Given this list of marker genes CMC1, P2RX7, ZNF627, ZCCHC12, WDPCP, TNFSF11, TMLHE, YPEL2 (NCBI Gene Id 388403), ARHGAP5, ZC3H7B, ANGPTL1, FBXL17, FUNDC1, DHX58, RCL1, IRF7, VPREB1, ACOX1, ZEB1, CLMP, CYP4V2, HSD17B11, ZNF365, RENBP, SNN, HSPH1, PKP4, EIF2AK1, BCOR, ALDOA, SASH3, TESC, FAM120B, SETD5, ASB7, FAM131A, MAP1B, C6orf118, DSE, ARRB1, KRTCAP3, MEAK7, IL6R, PPARGC1B, RIGI, TIGD2 (tigger transposable element derived 2), SELENOP, VPS13C, NBR1, ZNF711 (NCBI Gene Id 7552), CTNS, MZT2B, LIAT1, IQUB, TNIP1, GARIN3, MAPRE3 (microtubule associated protein RP/EB family member 3), NR3C2, RAB11FIP2 (NCBI Gene Id 22841), ZNF48, XAF1, MRPL23, TAF5L, CD2AP, MTR, CRTC1, DLG3, ZBTB4, XPC, KDM5B, GUCA1B, AKAP6, ICA1L, MYB, SESN3, LDLRAD4, CELF3, CALCOCO1, AVPR1A, RGMB, VRK1, MFSD9, GNPNAT1, RAMP3, TTC39C, STX4, ZCCHC24, TRPM1, MCCC2, CCDC141, CHDH, AFP (NCBI Gene Id 174), MTMR7, TNIP2, PTRH1 (NCBI Gene Id 138428), SH3RF1, OSGEP, KDM3B, SERAC1, INPPL1, MGARP, AGO1, IFT74, ASB3, DECR1, PFN2, ZNF106, SYT11, SLC25A36, CORO6, ISCA2, GADD45B, QPRT, TRPM6, CCR4, RNF19A, TRHR, BTBD2, DYNLT5, ATRAID, EVI5, KRT35, HES5, RWDD3, TNF, EXT1, WDR59, ANGPTL2, ZMYM4, FTL, HS1BP3, BAG5, NFKBIA, FAM168A, UBL5 (ubiquitin like 5), HSBP1, ATG2B, CTSS, NBN, PHF21A, MYCBP2, PFKM, CCDC91, ATP1B1, C19orf12 (chromosome 19 open reading frame 12), ARID5B, C1orf185 (chromosome 1 open reading frame 185), SLC3A1, DZIP1, SLC36A2, TGFB2, CTH, CALHM6, MAX, UTP14A, FAM217A, PCCA, XKRX, CDH23, ZNF518B, DNAL1, ART3, EGLN3 (egl-9 family hypoxia inducible factor 3), BPHL, TOX2, STAT1, OPALIN, AKAP11, TRMT1L, ABCG1, ZHX2, UBE2D1, TMPRSS4, CBX6, UBASH3A (ubiquitin associated and SH3 domain containing A), COMMD2, AREL1, HSPBAP1, C3orf33, WDFY2, SBSN, SLC26A2, GATAD2B, BCL6, LIPA, ZSWIM4, IFIT1B, MECR, TBC1D4, CYTH3, ST3GAL2, ARHGAP39, RASSF2, RUVBL1, TCEA2, SLC1A4, RGCC, MBNL2, FAM3D, OTUB2, here is a description of the gene set: Discrimination between self vs. non-self and adequate response to infection and tissue damage are fundamental functions of the immune system. The rapid and global spread of known and emerging viruses is a testament that the timely detection of viral pathogens that reproduce within host cells, presents a formidable challenge to the immune system. To gain access to a proper reproductive niche, many pathogens travel via the host vasculature and therefore become exposed to humoral factors of the innate immune system. Although a cascade of coagulation factors plays a fundamental role in host defense for “living fossils” such as horseshoe crabs (Xiphosurida spp), the role of the coagulation system in activation of innate responses to pathogens in higher organisms remains unclear. When human type C adenovirus (HAdv) enters the circulation, 240 copies of coagulation factor X (FX) bind to the virus particle with picomolar affinity. Here, using molecular dynamics flexible fitting (MDFF) and high resolution cryo-electron microscopy (cryo-EM), we defined the interface between the HAdv5 hexon protein and FX at pseudo-atomic level. Based on this structural data, we introduced a single amino acid substitution, T424A, in the hexon that completely abrogated FX interaction with the virus. In vivo genome-wide transcriptional profiling revealed that FX-binding-ablated virus failed to activate a distinct network of the early response genes, whose expression depends on transcription factor NFKB1. Deconvolution of the signaling network responsible for early gene activation showed that the FX-HAdv complex triggers MyD88/TRIF/TRAF6 signaling upon activation of toll-like receptor 4 (TLR4) that serves as a principal sensor of FX-virus complex in vivo. Our study implicates host factor “decoration” of the virus as a mechanism to trigger innate immune sensor that respond to a misplacement of coagulation FX from the blood into intracellular macrophage compartments upon virus entry into the cell. Our results further the mounting evidence of evolutionary conservation between the coagulation system and innate immunity. from publication Doronin K, Flatt JW, Di Paolo NC, Khare R, Kalyuzhniy O, Acchione M, Sumida JP, Ohto U, Shimizu T, Akashi-Takamura S, Miyake K, MacDonald JW, Bammler TK, Beyer RP, Farin FM, Stewart PL, Shayakhmetov DM (PMID 23019612) studied in species Homo sapiens Human Gene Set: GSE36078_UNTREATED_VS_AD5_INF_IL1R_KO_MOUSE_LUNG_DC_UP Genes up-regulated in Lung dendritic cell from untreated IL-1R mice versus Lung dendritic cell from Ad5 inf IL-1R mice.